The following is a description of a gene set: from publication Hollern DP, Swiatnicki MR, Andrechek ER (PMID 29346386) Human breast cancer has been characterized by extensive transcriptional heterogeneity, with dominant patterns reflected in the intrinsic subtypes. Mouse models of breast cancer also have heterogeneous transcriptomes and we noted that specific histological subtypes were associated with particular subsets. We hypothesized that unique sets of genes define each tumor histological type across mouse models of breast cancer. Using mouse models that contained both gene expression data and expert pathologist classification of tumor histology on a sample by sample basis, we predicted and validated gene expression signatures for Papillary, EMT, Microacinar and other histological subtypes. These signatures predict known histological events across murine breast cancer models and identify counterparts of mouse mammary tumor types in subtypes of human breast cancer. Importantly, the EMT, Adenomyoepithelial, and Solid signatures were predictive of clinical events in human breast cancer. In addition, a pan-cancer comparison revealed that the histological signatures were active in a variety of human cancers such as lung, oral, and esophageal squamous tumors. Finally, the differentiation status and transcriptional activity implicit within these signatures was identified. These data reveal that within tumor histology groups are unique gene expression profiles of differentiation and pathway activity that stretch well beyond the transgenic initiating events and that have clear applicability to human cancers. As a result, our work provides a predictive resource and insights into possible mechanisms that govern tumor heterogeneity. studied in species Mus musculus Genes that have high expression in paplillary mammary tumors. Mouse Gene Set: HOLLERN_PAPILLARY_BREAST_TUMOR, and this is the list of marker genes: Cnmd, Nrarp, Wnt5b, Hpgd, Hp (haptoglobin), Bbox1, Csn1s1, Pgap4, Aldh1a3, Armcx4, Krt19, Hey2, Ugt8a, Rhov, Muc15 (mucin 15), Wap, Cel, Slc43a3, Armcx2, Plce1